The following is a description of a gene set: studied in species Mus musculus Genes predicted to be targets of miRBase v22 microRNA mmu_miR_7030_3p in miRDB v6.0 with MirTarget v4 prediction scores > 80 (high confidence targets). from publication Chen Y, Wang X (PMID 31504780) Mouse Gene Set: MIR_7030_3P, and this is the list of marker genes: Zeb2, Slc30a4, Camk4, Gsta3 (glutathione S-transferase, alpha 3), Fcgr4, Tafa5, Bmi1, Kcnmb2 (NCBI Gene Id 73119), Zcchc14, Tbl1xr1 (transducin (beta)-like 1X-linked receptor 1), Cryba1, Gpr160, Slc4a7, Dennd11, Syne3, Ddit4l, Ube2f, Map7, Dclk1, Strbp, Mex3c (mex3 RNA binding family member C), Krt20, Chd9, Tex2, Srsf1, Tmem241, Tent4a, Chd6, Arhgap32, Bicral, Mbd2, Fgf12, Tspan7, Vgll3, Abhd4, Tmem33, Naf1, Jade2, Ptgs2, Rdh19, Rpl23, Acox1, Eloc, Rnf166, Epha5, Zfp236, Mmp16 (NCBI Gene Id 56518), Gabpa, Pgm2l1, Pnpt1, Cfap97, Glipr2, Ptpn5, Rapgef4, Zfp248, Rora, Dclre1c, Ptger1, Gphn, Pcdh19, Kmt5b (NCBI Gene Id 225888), Lhx2, Lpp, Pdlim5, Bcl2l1 (BCL2-like 1), Ptgdr2, Nav1, Smpx, Eif4b, Prpf4, Csnk1e, Manbal, Srcin1, Kctd4, Cdc42, Fndc5, Mip, Luc7l2, Asb5, Tial1, Rad54b, Cd200, Pfpl, Zcchc13, Snx31 (sorting nexin 31)